Given this list of marker genes Dock2, Srf, Foxn1, Skint1, Tox, Shh, Ptpn2, Ptprc, Cd74, Stk11, Itpkb, Zap70, Nfatc3, Cd3d, Cd1d1, Cd3e, H2-DMa, Cd3g (NCBI Gene Id 12502), here is a description of the gene set: Mouse Gene Set: GOBP_POSITIVE_THYMIC_T_CELL_SELECTION species: Mus musculus The process of sparing immature T cells in the thymus which react with self-MHC protein complexes with low affinity levels from apoptotic death.